Given this list of marker genes CHUK, IKBKB, IKBKG, here is a description of the gene set: part of: Diseases associated with the TLR signaling cascade Many signaling pathways rely on the activation of nuclear factor kappa B (NFkB), which is critical for the induction of the appropriate cellular function in response to various stimuli such as inflammatory cytokines, microbial products or various types of stress (Lawrence T 2009; Hoesel B and Schmid JA 2013). The NFkB family of transcription factors is kept inactive in the cytoplasm by inhibitor of kappa B (IkB) family members (Oeckinghaus A and Ghosh S 2009). Canonical NFkB activation depends on the phosphorylation of IkB by the I kappa B kinase (IKK) complex, which contains two catalytic subunits named IKK alpha, IKK beta and a regulatory subunit named NFkB essential modulator (NEMO or IKBKG) (Rothwarf DM et al. 1998). Phosphorylation of IkB leads to K48-linked ubiquitination and proteasomal degradation of IkB, allowing translocation of NFkB factor to the nucleus, where it can activate transcription of a variety of genes participating in the immune and inflammatory response, cell adhesion, growth control, and protection against apoptosis (Collins T et al. 1995; Kaltschmidt B et al. 2000; Lawrence T 2009).<p>IKBKG is encoded by an X-linked gene. Null alleles of the gene are lethal in hemizygous males, whereas hypomorphic alleles typically result in the impaired NFkB signaling in patients with a broad spectrum of clinical phenotypes in terms of both developmental defects and immunodeficiency (Döffinger R et al. 2001; Hanson EP et al. 2008). Several categories of mutations affecting IKBKG have been reported in humans (Döffinger R et al. 2001; Vinolo E et al. 2006; Fusko F et al. 2008). The first category of these mutations consists of hypomorphic mutations typically involving the zinc finger domain and nearby C-terminal regions and causing hypohidrotic ectodermal dysplasia with immune deficiency (HED-ID) in males (Jain A et al. 2001; Shifera AS 2010). The second category consists of amorphic mutations causing incontinentia pigmenti (IP) in females and, generally, prenatal death in males (Aradhya S et al. 2001; Fusco F et al. 2004). The third category is composed of hypomorphic mutations involving the stop codon causing anhidrotic ectodermal dysplasia with immunodeficiency (EDA-ID), osteopetrosis and lymphedema (OL-EDA-ID) in males (Döffinger R et al. 2001). Also some patients with a defective IKBKG gene can develop immunodeficiency without ectodermal dysplasia (Orange JS et al. 2004). This module describes several EDA-ID-associated hypomorphic IKBKG mutations that have been reported to affect inflammatory responses initiated by toll like receptors (TLR). Reactome Pathway: IKBKG deficiency causes anhidrotic ectodermal dysplasia with immunodeficiency (EDA-ID) (via TLR) species: Homo sapiens